Given this list of marker genes Atf2, Hspa5, Trp53, Hspb2, Jun, Rap1a, Fos, Ppp3r1 (NCBI Gene Id 19058), Casp1, Map2k4, Max, Mapt, Rasgrf2, Akt3, Dusp5, Traf6, Pdgfrb, Map3k12, Acvr1c, Dusp10, Tgfbr1, Stk3, Hspa1a, Map3k7, Ppp5c (protein phosphatase 5, catalytic subunit), Taok1, Egfr, Rac2, Mapk13, Map3k5, Taok2, Elk1 (NCBI Gene Id 13712), Map2k2, Atf4, Grb2, Hspa8, Mapkapk2, Raf1, Mapk1, Prkcg, Mapk4, Srf, Ngf, Mapk9, Map3k4, Egf, Ikbkb, Map3k20, Ppp3r2, Casp7, Mras (muscle and microspikes RAS), Arrb2, Akt1, Mapk12, Mos, Ptpn5, Gck, Il1a, Map3k14, Braf, Rasa2, Gadd45a, Il1b, Mink1, Tab2, Ddit3, Crk, Crkl, Pla2g5, Casp3, Nfkb1, Mapk8ip3, Map3k13, Ntrk1, Nlk (NCBI Gene Id 18099), Map4k4, Tgfb2, Dusp7, Ppp3cc, Mapk8, Nf1, Tgfb1, Fas, Rasgrp4, Mef2c, Cdc42, Cdc25b, Casp8, Il1r1, Map3k6, Map2k6, Flna, Kras, Ptpn7, Daxx, Akt2, Mapkapk5, Acvr1b, Casp9, Jund (jun D proto-oncogene), Pak2, Rap1b, Prkcb, Map3k1, Map2k1, Dusp1, Map3k8, Tab1, Map2k5, Dusp6, Rps6ka3, Hspb1, Pdgfb, Map2k7, Traf2, Il1r2, Prkcz, Ppp3ca, Rasgrp1, Mapk14, Map4k3, Myc (myelocytomatosis oncogene), Casp6, Pla2g10, Tmem37, Ppm1b, Rasa1, Ppp3cb, Fgf4, Rac1, Mapk10, Arrb1, Nras, Mapk3, Cd14, Ikbkg, Fasl, Pak1, Ppm1a, Ntf5, Map4k1, Mapk6, Dusp4, Tgfbr2, Prkch, Tgfb3, Prkcd, Ptprr, Map3k11, Sos2, Casp2, Gna12, Stmn1 (stathmin 1), Prkaca (NCBI Gene Id 18747), Mapk7, Bdnf (brain derived neurotrophic factor), Tnf, Nr4a1, Ecsit, here is a description of the gene set: Mouse Gene Set: WP_MAPK_SIGNALING_PATHWAY Mapk signaling pathway studied in species Mus musculus